The following is a description of a gene set: species: Homo sapiens Human Gene Set: GOMF_CARDIOLIPIN_BINDING Binding to cardiolipin., and this is the list of marker genes: MME, GSDMB, UQCC3, ATP8B1, GSDME, OPA1, PLEKHN1, UCP1, STOML2, GSDMD, IRGM, NME4, SPATA18, RPE65